The following is a description of a gene set: Catalysis of the removal of a methyl group from a tri- or a dimethyl-lysine residue at position 27 of the histone H3 protein. This is a dioxygenase reaction that is dependent on Fe(II) and 2-oxoglutarate. Human Gene Set: GOMF_HISTONE_H3K27ME2_H3K27ME3_DEMETHYLASE_ACTIVITY studied in species Homo sapiens, and this is the list of marker genes: KDM6B, PHF8, UTY, KDM6A, KDM7A